Given this list of marker genes Srcap, Prmt8 (NCBI Gene Id 381813), Gnal, Tbpl1, Sobp, Phip, Spon2, Stk26, Laptm5, Tent5b (terminal nucleotidyltransferase 5B), Dgkb, Rangap1, Arsb, Zfp958, R3hdm2 (R3H domain containing 2), Zbtb4 (zinc finger and BTB domain containing 4), Tnrc6a, Crisp3, Rpl14, Rbm41, Cd300lb, Cfap298, Chd3, Garin1a, Srm, Rhbdd1, Czib, Ccn2, Pknox2, Clec16a, Pbx3, Gpm6b, Slc8a3, Dydc1, Brca1, Lrrfip1 (leucine rich repeat (in FLII) interacting protein 1), Hmg20a, Elapor2, Cacna1e, Mknk2, Reps2, Gpr158, Dtna, Castor2, Sema6d, Crisp1, Slc6a8, Or5d38, Psapl1, here is a description of the gene set: species: Mus musculus Genes predicted to be targets of miRBase v22 microRNA mmu_miR_6952_5p in miRDB v6.0 with MirTarget v4 prediction scores > 80 (high confidence targets). Mouse Gene Set: MIR_6952_5P from publication Chen Y, Wang X (PMID 31504780)